Given this list of marker genes PDZK1IP1, CD99L2, TSPAN15, WDR72, LMO4, ITPKA, ADCYAP1R1, CGNL1, POF1B, LTK, MAP3K13, here is a description of the gene set: Human Gene Set: HOLLERN_SOLID_NODULAR_BREAST_TUMOR_UP Genes that have high expression in mammary tumors of solid nodular histology. from publication Hollern DP, Swiatnicki MR, Andrechek ER (PMID 29346386) Human breast cancer has been characterized by extensive transcriptional heterogeneity, with dominant patterns reflected in the intrinsic subtypes. Mouse models of breast cancer also have heterogeneous transcriptomes and we noted that specific histological subtypes were associated with particular subsets. We hypothesized that unique sets of genes define each tumor histological type across mouse models of breast cancer. Using mouse models that contained both gene expression data and expert pathologist classification of tumor histology on a sample by sample basis, we predicted and validated gene expression signatures for Papillary, EMT, Microacinar and other histological subtypes. These signatures predict known histological events across murine breast cancer models and identify counterparts of mouse mammary tumor types in subtypes of human breast cancer. Importantly, the EMT, Adenomyoepithelial, and Solid signatures were predictive of clinical events in human breast cancer. In addition, a pan-cancer comparison revealed that the histological signatures were active in a variety of human cancers such as lung, oral, and esophageal squamous tumors. Finally, the differentiation status and transcriptional activity implicit within these signatures was identified. These data reveal that within tumor histology groups are unique gene expression profiles of differentiation and pathway activity that stretch well beyond the transgenic initiating events and that have clear applicability to human cancers. As a result, our work provides a predictive resource and insights into possible mechanisms that govern tumor heterogeneity. studied in species Homo sapiens